The following is a description of a gene set: The effect of human cytomegalovirus (HCMV) infection on cellular mRNA accumulation was analyzed by gene chip technology. During a 48-h time course after infection of human diploid fibroblasts, 1,425 cellular mRNAs were found to be up-regulated or down-regulated by threefold or greater in at least two consecutive time points. Several classes of genes were prominently affected, including interferon response genes, cell cycle regulators, apoptosis regulators, inflammatory pathway genes, and immune regulators. The number of mRNAs that were up-regulated or down-regulated were roughly equal over the complete time course. However, for the first 8 h after infection, the number of up-regulated mRNAs was significantly less than the number of down-regulated mRNAs. By analyzing the mRNA expression profile of cells infected in the presence of cycloheximide, it was found that a minimum of 25 mRNAs were modulated by HCMV in the absence of protein synthesis. These included mRNAs encoded by a small number of interferon-responsive genes, as well as beta interferon itself. Cellular mRNA levels in cytomegalovirus-infected cells were compared to the levels in cells infected with UV-inactivated virus. The inactivated virus caused the up-regulation of a much greater number of mRNAs, many of which encoded proteins with antiviral roles, such as interferon-responsive genes and proinflammatory cytokines. These data argue that one or more newly synthesized viral gene products block the induction of antiviral pathways that are triggered by HCMV binding and entry. from publication Browne EP, Wing B, Coleman D, Shenk T (PMID 11711622) Human Gene Set: BROWNE_HCMV_INFECTION_20HR_UP species: Homo sapiens Genes up-regulated in primary fibroblast cell culture after infection with HCMV (AD169 strain) at 20 h time point that were not up-regulated at the previous time point, 18 h., and this is the list of marker genes: DFFB, IFNA5, HUS1, EDA, SRRT, RELA, GUCY1B1, DLX2, IREB2, STARD3, ERBB3, TRIM26, ZNF263, MUC7, KCNH2, SIAH2, DUSP7, PTPN21, COL2A1, ARHGAP44, GAB1, MAP3K13, UBE2H, FXR2, WWC1, EFNA4, SULT1A2, BCL7B, OGFR, CCR1, DNAJA1, H2AX, ARK2N, ZNF267, RNF19B, ZFY, EYA2, RNF40, CDKL5, ARHGAP32, TFRC, ZNF131, CASP7, RABGAP1L, CDK20, CELF1, REL, AHCTF1, NR4A3, ZNF101, CLUH, USP6NL, PAK3, H3C10, TUBA4A, ZBTB43, NTRK2, IL27RA, CHST2, PPP2R5B, CLOCK, RET, HCN2, SEPTIN4, PCDH9, ABAT, HES1 (NCBI Gene Id 3280), LYN, SMG1, FRRS1L, PTPRE, PROX1, SH2B2, POT1, PGM3, CBARP, CDC5L, KPNA6, MSX1, GPR37, RUNX3, ZNF593, HYAL2, RAP2C, ETS2, SMARCD2, FOXO1, TFEC, ARFIP2, CBX4, GP1BB, DOCK3, TMPO, TOX3, ERC2, E2F6, USP6, PML, BAP1 (NCBI Gene Id 8314), ERP44, ERF, NFATC1, CA2, EN2, UBE2M, ATXN2L, INPP1, TMSB15A, NACAD, GNAZ, UBE2S, ZNF202, GOSR2, MAP2K4, IGFBP2, SAFB2, STIMATE (STIM activating enhancer), PLAGL2, MLXIP, CHST10, ZBTB18, LCN2, DUSP3, ALAS1, PANK3, ABCF3, IMPA1, SRSF3, XAF1, LZTS3, PCDHGA12, ELK4, CCNC, ZPR1, PBX2, THOC1, NFATC3, SLC6A6, TGFBRAP1, TEAD4, HSPA2, GTF2A1, CCND3, ZNF37A, ATXN7L3B, DDX52, PLAAT3, PRPF19, CLGN, TFDP2, ZNF41, GAS7, CDC34, ZNF273, ZBTB5, PDK3, SOX5, RHOB, MTF1, GNL1, PRP4K (pre-mRNA processing factor kinase PRP4K), CGGBP1, WASL, PDE4A, NRGN (neurogranin), ZNF391, MAPT, BRD2, GBF1, RAB5A, EED, YLPM1, ADAMTS3, DOHH, GNA13, CDR2L, MAP3K3, BRAF, ATP1A3, FURIN, PCGF3, CDKN2B (cyclin dependent kinase inhibitor 2B), PPARA, TTBK2, PRKACA, PTPN11, SLC25A20, B4GALT5, PTPRD, NKX2-5, EFNB2, TRIM33, TRMU, SLC6A8, RAP2A, C4BPB, MPDU1, APOE, MED6, SNRK, ABCB1 (ATP binding cassette subfamily B member 1), PIP5K1B, ZNF204P, DUSP8, CYRIA, TAF6L, VEGFA, CHMP7, SLC22A5, SEPHS1, PLCL1, TEX30, TSR1, MPP2, GSTM3, OAS2, CDK2AP2, ATRN, BAK1, AKAP8L (A-kinase anchoring protein 8 like), KIF5C, PTPRB, UBE3A, TIAM1, SIKE1, KHDRBS3, RNF126, TRIM52, BTRC, CCDC181, TOE1, TRIM21, NEFL, MARK2, NFKB2